The following is a description of a gene set: A toe that appears disproportionately short compared to the foot. Short toe Human Gene Set: HP_SHORT_TOE studied in species Homo sapiens, and this is the list of marker genes: DNMT3A, FLNA (filamin A), EOGT, SPECC1L, BMPR1B, IL2RG, BPNT2, ALOXE3, TGDS, PDE4D, CHST11, SOX9, NELFA, BMP2, SVBP, B3GLCT, ERI1, ASXL1, CTCF, NSD2, DHCR7, CPLX1, RAG2 (recombination activating 2), KCNH1, GDF5, CHSY1, COX4I1, SALL4, KCNJ8, IFT140, IL7R, HOXD13, PTH1R, KMT2A, HDAC4, ASAH1, FLI1, FGFR3, RBPJ, UBAP2L, GPX4, DCLRE1C, TRPV4, FGFR2, PIGG, IFT122, GRIP1, LETM1, HEATR3, ASCC3, VAC14, NOTCH2, ACVR1, ZMIZ1, SF3B4, MIA3, ADA, TPR, PIGV, FGFR1, RNU4ATAC, ADNP, TBX3, TNNT3, COL2A1, PIGF, SLC26A2, NOG, ALOX12B, MYCN, GJA1, SMAD4, NPR2, FGFRL1, GPC3, SHOX, EP300, MGP, HBA2, IHH, ERF, OFD1, RAB3GAP2, ADAMTS2, GHR, CTBP1, TBX22, EIF4A3, ARSL, DYRK1A, ABCC9, PHF6, PRKAR1A, GNAS, ALMS1, ROBO1, BHLHA9, KAT6A, LIG4, GPC4, CHD7, C12orf57, PUF60, TBL1XR1, RMRP (NCBI Gene Id 6023), WASF1, HOXA13, FIG4, HBA1, ZFX, PRKG2, RAG1